The following is a description of a gene set: Hypoxia-inducible factor 1 (HIF-1) activates transcription of genes encoding angiogenic growth factors, which are secreted by hypoxic cells and stimulate endothelial cells, leading to angiogenesis. To determine whether HIF-1 also mediates cell-autonomous responses to hypoxia, we have compared gene expression profiles in arterial endothelial cells cultured under nonhypoxic versus hypoxic conditions and in nonhypoxic cells infected with adenovirus encoding beta-galactosidase versus a constitutively active form of HIF-1alpha (AdCA5). There were 245 gene probes that showed at least 1.5-fold increase in expression in response to hypoxia and in response to AdCA5; 325 gene probes showed at least 1.5-fold decrease in expression in response to hypoxia and in response to AdCA5. The largest category of genes down-regulated by both hypoxia and AdCA5 encoded proteins involved in cell growth/proliferation. Many genes up-regulated by both hypoxia and AdCA5 encoded cytokines/growth factors, receptors, and other signaling proteins. Transcription factors accounted for the largest group of HIF-1-regulated genes, indicating that HIF-1 controls a network of transcriptional responses to hypoxia in endothelial cells. Infection of endothelial cells with AdCA5 under nonhypoxic conditions was sufficient to induce increased basement membrane invasion and tube formation similar to the responses induced by hypoxia, indicating that HIF-1 mediates cell-autonomous activation of endothelial cells. species: Homo sapiens from publication Manalo DJ, Rowan A, Lavoie T, Natarajan L, Kelly BD, Ye SQ, Garcia JG, Semenza GL (PMID 15374877) Genes up-regulated in response to both hypoxia and overexpression of an active form of HIF1A. Human Gene Set: MANALO_HYPOXIA_UP, and this is the list of marker genes: TCF7L1, NPAS2, SPOCK1, MAST4, USP47, B3GALT4, ALPK3, CD200, MMP2, ADM, MN1, BACE2, TMEM45A, N4BP3, PXN, LOX, PELI2, ITPR2, GYPC, MARCHF3, ADORA2A, ZNF710-AS1, NUAK1, IGFBP3, HTRA1, DCHS1, SOX4, CCNG2, EDN1, PLOD2, RAI14, CXCR4, CASK, STC1, FILIP1L, BNIP3, SEPTIN4, MYH13, GABRP, CDK19, ATP2C1, CUBN, RPS6KA2, CHST1, PTPRF, GADD45B, NDRG1, ACKR3, GAS6, PGM3, COL4A2, VWF, NEDD9, GRAMD1C, MTHFD2L (NCBI Gene Id 80068), RRAS, VLDLR, DUSP6, FNDC3B, NOTCH4 (NCBI Gene Id 4855), SORBS2, TNS1, LIMS1, NAP1L1 (NCBI Gene Id 64165), PGM1, GJA5, ATXN1, EGLN3, FKBP9, VEGFA, NARF, RLN1, ENPP1, ARL4C, COL1A2, TPM1, PTPRR, PPARG, TNFAIP3, WASF2, AK4, EPOR, PPP1R13L, BGN, TAPBPL, GDF10, CHSY1, HLA-B, SPAG4, NPR1, ZNF292, KLF11, P4HA2, NYNRIN (NCBI Gene Id 80151), TLE1, TSKU, EGLN1, TXNIP, DDIT4, COL9A1, LAMB1 (laminin subunit beta 1), FAM171A1, LOXL2, CREB3L2, PLEKHO1, INSR, NINJ2, TGFBI, RGS3, TP53TG1, COL4A1, ABCA1, PAM, RNASE4, SIK1, RHOBTB1, SERPINE1, LRRC32, KDM3A (lysine demethylase 3A), PTGIS, ACVR1B, CELF2, LIMCH1, DLGAP4, CLIP2, SYNPO, SIRT3, STC2, CDH2, INHBA, ERO1A, TSGA10, HLA-E, COL18A1, MEF2A, ZNF395, F8, TNFRSF10B, PLCG2, MAGED2, ALDH2, SLC6A8, GLCE, INHBE, ITM2A, SLC2A3, HES1, TRIB2, KANK3 (KN motif and ankyrin repeat domains 3), MAFF, RASSF2, ANGPTL4, RBKS, TNFRSF14, BNIP3L, CDKN1C, GBE1 (1,4-alpha-glucan branching enzyme 1), SPSB1, PDGFB, PLOD1, AXL, NMRK1, PTGS1, LEPR, PTPRB, TENT5A, SEC24A, MTSS1, COL5A1, SMAD6, NFASC, ENO2, TRIO (NCBI Gene Id 7204), APOD, PDZD2 (NCBI Gene Id 23037), GLS, BHLHE40, AFAP1, GPNMB, PGF, TCIM, VEGFC, MXI1, CHST15, GPC1, ZBTB1 (zinc finger and BTB domain containing 1), SV2C, CX3CL1, BCL6, HIF3A, DKK3, IDH2, IER3, OPN3, TMCC1, HIVEP2, FER1L4, P4HA1, CYP4F11, GRK5 (G protein-coupled receptor kinase 5), NFATC4, DIAPH2 (NCBI Gene Id 7989), SLCO5A1, SHOX2, ZHX2